Given this list of marker genes H2BC5, H2AC4, TPR, SEC13, LEMD2, NUP62, CCNB2, NUMA1, GORASP1, MAPK1, PPP2CB, NUP98, NUP50, NUP85, PPP2R1B, CCNB1, EMD, NUP153, PRKCA, SEH1L, TMPO, SET (SET nuclear proto-oncogene), NUP93, ARPP19, H2BC1, H3-4, NDC1, H4C1, H2AC7, NEK6, LPIN3, H2BC13, RAB1B, BANF1, MASTL, H2BC21, LMNA, H2BC12, RAE1, MCPH1, PRKCB, VRK2, H2AC6, CTDNEP1, AAAS, NUP155, NUP160, H2BC3, NUP107, NUP58, NUP188, GOLGA2, RANBP2, PLK1, NUP210, H2AC20, CNEP1R1, NUP43, VRK1, PHF8, USO1, LMNB1, H2BC11, RB1, LPIN2 (lipin 2), CDK1, PPP2R2D, H2BC14, H2BC17, H3-3A, SMC4, BLZF1, PPP2CA, NCAPD3, ENSA, LPIN1 (lipin 1), NUP88, H2AC14, H2BC26, RAB2A, SMC2, NCAPG2, POM121C, NUP42, PPP2R1A, KMT5A, H2AZ2, NUP37, NUP214, H3C1 (H3 clustered histone 1), H2BC12L, POM121, H2AJ, RAB1A, GORASP2, NUP35, NUP133, LEMD3, NUP205, H2BC4, NUP54, NEK9, H2AB1, H2AC18, NEK7, H2AX, MAPK3, H2BC15, NCAPH2, H3C15 (NCBI Gene Id 449003), H2BC9, here is a description of the gene set: During prophase, the chromatin in the nucleus condenses, and the nucleolus disappears. Centrioles begin moving to the opposite poles or sides of the cell. Some of the fibers that extend from the centromeres cross the cell to form the mitotic spindle. Reactome Pathway: Mitotic Prophase part of: M Phase species: Homo sapiens